Given this list of marker genes COL2A1, COL6A1, PDGFA, COL4A1, MMP9, BMP5, VDR, TGFB3, AHSG, FGFR2, COL4A2, MMP2, BMP1, PHEX, TUFT1, COL5A1, TGFB2, here is a description of the gene set: Human Gene Set: KANG_AR_TARGETS_UP from publication Kang HY, Shyr CR, Huang CK, Tsai MY, Orimo H, Lin PC, Chang C, Huang KE (PMID 18838539) While androgen receptor (AR)-deficient mice developed osteopenia in endochondral bones due to the high bone turnover with increased bone resorption by osteoclasts, little is known about the mechanism of intramembranous bone loss contributed by AR in osteoblasts. Here, we discovered a dramatic decrease in the area of calcification, new bone, and the number of osteocytes in calvaria from AR-deficient mice related to a reduction in mineralization caused, in part, by the diminished activity of AR-deficient osteoblasts. Enforced AR expression in differentiated osteoblasts boosts mineralization while knockdown of AR expression prevents androgen-induced mineralization. We identified the tissue-nonspecific alkaline phosphatase (TNSALP) and several members of small integrin binding ligand N-linked glycoprotein (SIBLING) gene family as androgen target genes required for AR-mediated bone formation. We show that inorganic phosphate (P(i)) levels and TNSALP activity increased in response to androgen/AR and P(i) signals increase the expression and translocation of AR. The ectopic expression of TNSALP or P(i) partially rescued the bone loss due to AR deficiency. Thus, androgen/AR signaling plays an essential role in bone formation by coordinating the expression of genes associated with phosphate regulation. Genes up-regulated in osteoblasts from wild type male mice compared to those with AR knockout. species: Mus musculus